The following is a description of a gene set: species: Homo sapiens Mouse CD8+ T cells affected by ID3 (Inhibitor of DNA binding 3) display patterns of gene expression suggesting enhanced persistance and survival. In this study, we identified genes differentially expressed between ID32a transduced and mock transduced, and ID32a knockout and wild type mouse CD8+ T cells. Most prominent functions of differentially expressed genes include DNA replication-associated repair, maintenance of chromosome stability and mitotic cell divison machinery. Overall, these data suggest that ID3 acts in favor of maintained survival in CD8+ mouse T cells. from publication Ji Y, Pos Z, Rao M, Klebanoff CA, Yu Z, Sukumar M, Reger RN, Palmer DC, Borman ZA, Muranski P, Wang E, Schrump DS, Marincola FM, Restifo NP, Gattinoni L (PMID 22057288) Genes up-regulated in CD8 T cells: ID3 knockout versus wildtype. Human Gene Set: GSE23568_ID3_KO_VS_WT_CD8_TCELL_UP, and this is the list of marker genes: KIF11, FGL2 (NCBI Gene Id 10875), ROM1, GEMIN5, MAP3K8, CCNB2, ATP5MK, ARPP19, DTYMK, NDUFB3 (NCBI Gene Id 4709), RFC5, TIMM8B, UBXN1, MAD2L1, TXNL1, RACGAP1, TACC3, MYO1F, BCL2L11, SEC13, CBX5, YJU2, EIF3B (NCBI Gene Id 8662), SSX2IP, MRPL41, RDH11, YBX3, SIRT3, KMT5A, CDCA8, HMGB2, CUEDC2, SNHG6, TFPI, NCAPH, HMGB3, NUSAP1, LIG1, RGL1, CHEK2, BLM, SEC61G, MRPL51, CCL5, PRPF31, NDUFAB1, CPD, CD8A, FABP5, ANAPC16, DCPS, ITGAE, TBC1D24, ORC6, TOP2A, AMZ2, NDUFA5, DTL, SLC31A1, SET, RHOQ, PSMB3, CCR9, RPS26, DDC, ELOVL6, CD160, GCLM, UFC1, MIEN1, KIT, KCTD9, RWDD1, MX1, NIPSNAP2 (nipsnap homolog 2), AHR, KLRK1, CKS1B, S100A11, DHRS1, CD7, PDCD5, YIPF4, BPNT2, NEDD4, CDC20, SIN3B, MKI67, DUSP16, GMPPB, CCDC28B, POLD2, ASPM, CDCA5, CXXC5, CAPNS1 (NCBI Gene Id 826), S100A10, TXN, GATD3, CIP2A, DLGAP5, PPIA, ASF1B, TCF19, TRIP13, TTK, CD244, MCOLN2, ANAPC13, POLR2D, ARPC3, NEDD8, SEM1, CKS2, NUDT1, ECH1, GSTO1, LMNB1, LAGE3, POLA1, U2AF1, CA2, POLR2K, YARS1, CAPN3 (calpain 3), OSBPL5, CST7, SASS6, BUB1, CHEK1 (NCBI Gene Id 1111), ALYREF, ATP5IF1, CDT1, PLAC8, GZMB, MTM1, PLP2, ST3GAL4, RPL36A, MARCKS, CISD1, MVD, S100A1, UCK2, UNC119B, CTSW, BIRC5, PRKACB, AURKA, SNRPB2, ANXA2, PTTG1, RASD1, NEK2, UNC119, BCKDHA, ADAM19, POLR3K, UQCC3, DHFR, PSPH, RPIA, RFC3, GOLIM4, MCM7, GYG1, SELENOH, SYCE2, ANLN, MRPL27, CYB5B, TM2D2, IMPA2, NRGN, COL4A1, SAR1B, HHEX, SNAP23, CENPK, STMN1, TFDP1, DRC1, CHCHD7, ZNF239, PSMB6, PCLAF, BAX, MRPS28, RFC2, KDELR2 (KDEL endoplasmic reticulum protein retention receptor 2), GABARAPL1, COQ7, TNFRSF18, TSC22D1, KLRD1, CDK1, SOD2, CDC6, SPAG7 (sperm associated antigen 7)